The following is a description of a gene set: species: Mus musculus Any process that modulates the frequency, rate or extent of hematopoietic progenitor cell differentiation. Mouse Gene Set: GOBP_REGULATION_OF_HEMATOPOIETIC_PROGENITOR_CELL_DIFFERENTIATION, and this is the list of marker genes: Hmgb1, Zbtb1, Sos2 (SOS Ras/Rho guanine nucleotide exchange factor 2), Sos1, Mettl3, Dpf2, Vegfa, Nfe2l2 (nuclear factor, erythroid derived 2, like 2), Ankle1, Notch1, Pdcd2, Mixl1, Nudt21, Rara, Gata2, Znhit1, N4bp2l2, Hspa9, Hes5, Myb, Kdr, Fas, Flt1, Eif2ak2, Tcf15, Kitl, Tmsb4x, Prkdc, Fnip1, Mettl14, Pus7, Kat5, Setd1a, Hes1, Dhx36, Ap2a2, Foxc1, Il3, Spi1, Pcid2, Cdk6, Ythdf2, Zfp36, Flcn (NCBI Gene Id 216805)